Given this list of marker genes RALGPS2, FPGS, VPS35, SEPSECS, ASB4, IMPACT, SLC31A2, RHOU, TRAF3, SERP1, FA2H, ASCC2, GFPT2, SLC7A14, TPST2, GGPS1, CNTN1, FRMD4B, NECAP2 (NCBI Gene Id 55707), EYA1, RELA, AKT1S1, REEP1, ESYT2, ELK4, NIBAN2, LRRC57, SLC25A39, DENND6A, LRIG1, ETNPPL, SLC35B2, BCAT1, IPO8, MYORG, FAM53B, ZKSCAN4, ITGA7 (NCBI Gene Id 81988), TFEB, ENPP4, IL9R, CDCA7, FMC1-LUC7L2, RYR2, MOCS1, GLRB, ENAH, KCNK2, CDH2, BLOC1S6, CHST14, NRP1, CDK6, SLC39A9, FAM177A1, CCDC28A, RASGEF1A, KIF13B, TTL, ROCK1, GPATCH8, ZCCHC24, SERTAD3, SLITRK6 (SLIT and NTRK like family member 6), GRID1, TRIM49D2, RAPGEF1, ZSCAN22, TMEM134, ATF7, MAPK14, GLCE, NR4A1, FAM78B, HADHA, CTDSP1, RCOR1, OSBPL11, SNX18, MYRIP, PLSCR3 (phospholipid scramblase 3), CHST1, UNC119B, NAP1L5, PLEKHM3, MIGA1, MEF2A (NCBI Gene Id 4205), ITPR3 (inositol 1,4,5-trisphosphate receptor type 3), GARIN1A, RNF128, ANKRD27, STEAP3, BCL7A, PGM2, PLEKHF2, P4HA1, RALGDS, ITPRID2, CHIC2, FURIN, SGPP1, MYH11, BTBD10, CPD, VPS37C, APLN, ABCC4, CNKSR3, TRIM49C, RAB3D, ZFP36L2, PCSK6, SGMS1, JAKMIP3, G3BP1, FAM78A, SUCLG2, RFX3, ZBTB20, TRIB3, FLOT1, VAT1, FBXO38, RASSF8, DLX3, TARBP1, FRMD6, PROX1, USP2, DLL4, SPTLC1, TET1, PPP1R13L, HIVEP1, CCDC89, APBB2, ANAPC7, ABT1, SERTAD4, YEATS2, BCL2L13, STOM, ADCY9, RAD17, TADA2B, BCL11B, PML, RHOG, CDH4, CLMP, IREB2, SESTD1, CEBPA, NFIX, KIAA1671, FLRT3 (NCBI Gene Id 23767), SLC2A13, JAM2, LRRC1, WNK1, PARP8, MYRF, GATA6, GDAP1L1, PTPN14, PLXNB2, CAV1, PRKAG2, ANKLE2, PRTG, PAQR9, CLOCK, CADPS (calcium dependent secretion activator), SHC1, TUB, SHANK2, RASSF3, RWDD4, SGK1, ZMPSTE24, TMEM178A, VIM, GDAP2, WDR44, CHP1, CUL5, PTBP1, STON2, CYP2R1, SLITRK4, PARD3, MAGT1, SNTA1, GCDH, XKR6, FAM199X, GIT2, FAM171A1, WDFY3 (WD repeat and FYVE domain containing 3), RALA (NCBI Gene Id 5898), LIMS1, SLC17A5, DSG2, SUSD6, SRGAP1, FAR1, FERMT2, CHIC1, PNPLA2, RAB11FIP1, NFIC, KATNBL1, CLDND1, SPOPL, SH2B3, RNF217, SLC7A1, EYA3, MARCHF8, TMEM150A, KIF2A, CDCP1, NFIB, LUC7L2, NID1, DYRK2, HECTD2, SAP30L, SMOX, PTPRZ1, KCNJ6, PTPRQ, PGRMC2, STT3A, RAI14, SLC33A1, CALCOCO1, MTR, CSPP1, IL6R, SBNO2, NAPEPLD, MAN2A1, MBNL3 (muscleblind like splicing regulator 3), SNIP1, PABPC4L, HTATIP2, GZF1, ZNF503, MORC4, VAMP3, RPIA, WIPF1, TEAD1, NEMP1, MAP3K1, KCTD8, GLI3, TBC1D9B, MED26 (NCBI Gene Id 9441), CBX2, PHACTR2, RAB10, TOR3A, CYB5A, EVI5, HADH, AMMECR1, LPP, GCH1, NAA15, PHKA1, NR5A2, SLC25A38, SVIP, KLHL24, SPCS2, TNFSF15, SGCZ, ASPA, PSKH1, TMEM248, ZMAT3, MAP3K2, CREB3L2, GSN, ARL5B, TRIM49, SLC15A4, TMEM109, TSKU, FCHSD2, SSH1, CTDSPL, CREBRF, FAM120C, FRMD8, RRAGD (Ras related GTP binding D), SLC31A1, SH3KBP1, PRDM13, SEC13, SEMA6A, LAMP2, B4GALT1, PAQR8, RBL1, ENY2, SCAMP4, ATF7IP, RNPEPL1, ZKSCAN8, EDNRB, ETS1, WASF1, GGA2, TWSG1, RAVER1, HIPK3, KPNA3, SLC13A1, GRIA4 (NCBI Gene Id 2893), SLC9A9, OSBPL8, CASQ2, UBE2G1, MAPK4, TLL1, PAM, SUGT1, PIP4K2C, FLOT2, RPS6KA1, MTM1, PPP1R3B, LCLAT1, SHC3, DMD, GNG2, FSBP, PIK3C2A, MKX, CCDC177, CCDC86, AP1M2, PABIR2 (NCBI Gene Id 159090), TMEM104, MLXIP, GXYLT1, KAT7, UNC5D, TEX261 (testis expressed 261), XPO4, EDEM1, RAB34, SEPTIN10, PPARA, HIPK1 (homeodomain interacting protein kinase 1), ARFIP1, MYZAP, MINAR1, USP14, RAB3GAP1, TLN1, PAPOLG, GNAI1, ATMIN, C9orf72, PIEZO2, PHF8, CGN, ATP6V0E1, PLEC, RSRC2, FNBP1, SGPL1, AHR, TOR1AIP2, HEBP2, NYNRIN, SLC30A7, DMRT1, PPIF, OSBP, KIAA2013, DCTN4, WASF2 (NCBI Gene Id 10163), PRRX1, ERN1, QSER1, RBMS3, IRF2BPL, UBE3A, SLC44A5, KCNK10, GTF2A1, MGAT4A, GALNT10, TSC22D4, CD164, FZD4, TFDP2, IQGAP2, LIF, USP30, RAD54B, PPM1F, SOX8, HMGXB4, CPT1A, DLX5, GMNC, AKT3, NFATC1, ADNP2, ZBED4, NR3C2, USP45, RAB22A, CDH9, SREK1, CDON, SDF2L1, OGFOD3, ZNF219, SMARCAD1, TMBIM1, WTAP, KIF26A, PCDH8, MYO1C, TMED1, IAPP, FARP1, MTCL2, GPT2, EPS8, CBFB, MYADM, RAPH1, SNX30, SERTAD2, PALLD, GPAM, XYLT1, PDPR, MIB1, GRIA3, EEA1, RIF1, PKN2, SLC50A1, ARHGDIA, SLC10A7, TP53INP1, STK38, MITF, COL4A1, THRB, TMEM87B, CASP9, RBM20, MYLIP, EML6, PIM1, PTBP3, ILDR2, PI4K2B, CBL, KIF3A, PARP14, ZNF608, CPA3, PLOD3, THAP2, JADE1, THSD7B, IQGAP1, UBQLN3, SFT2D2, DNAJC1, MYH10, ACAA2, SLC35A4, ELAPOR2, NFATC2, TMEM184B, RBM47, ABHD5, NSUN2, CAPN6, SMAD5, SEMA6D, CXADR, ACADVL, POC1B, ELOVL5, ARMC1, SNAP29, HIVEP3, SCAMP2, SLC9A2, ORC2, JAG1, BPNT2, NAT8L, PTTG1IP, ATP1A1, BACH2, ROR2, RNF19A, SELENOI, ELL2, SNX16, TMC7, CHODL, RARG, ANXA5, ACTN4, RYR3, EYA2, TNRC6B, LITAF, TRIM49D1, SUCO, PLP2, ZFP36L1, RNF135, GOLM2, HEATR1, QKI, KIF26B, CCDC198, SYT14, TRIM48, IFFO2, RYK, ANTXR2, C2orf68, C2CD3, PRLR, L2HGDH, PTPRD, SIGMAR1, RIOX2, SLCO5A1 (NCBI Gene Id 81796), AMOTL1, PTBP2, OSBPL10, RBMS1, MYO10, LRRC58, CNEP1R1, ERMP1, OAF, RDH10, KLF6, SORD, RAB38, CPNE3, C1GALT1, LDLRAP1, GMFB, GPR37, MICAL2, MYH9 (NCBI Gene Id 65212), PTPN12, SLC16A13, SLC25A30, FKBP15, SERINC2, EYA4, E2F5, NEK6, AFF4, ZNF131, BMP6, CDK13, RREB1, ATP7A, ECI2, RAB27A, UBE4A, TSHZ1, OSBPL3, PTPN9, ANKRD44, PLEKHH1, ATP6V0A2, NEURL1B, ATL3, SH3PXD2A, FCHO2, TMCO3, NCOA4, LAMC1, GNG10, CD151, ITGA3, FSTL5, GNAL, PECR, PARP16, CAPN2, LCP1, ZWINT, SEPTIN9, NTAQ1, RYR1, HDAC4, CTNND1 (NCBI Gene Id 82168), RHBDF1, TMEM35B (transmembrane protein 35B), TRIM45, RFX4, CAPN1, SNAI2 (NCBI Gene Id 6591), LIMCH1, TRAM2, ZDHHC3, SOS2, CPNE5, SUMF1, PDLIM5, TTC7A, RAB11FIP5, POLR3G, NMNAT1, PAPSS2, ZNF706, MBOAT2, C2orf88, WIPF2, SPINDOC, ARHGEF37, RGS9 (regulator of G protein signaling 9), LEMD3, RBM33, SLC66A3, FMOD, CUX1, SLC1A4, ECE1, MYO1E, USP1, ULK2, GALNT13, C2orf69, LPCAT3, ELK3, ALDH9A1, DNAJC25-GNG10, ENDOD1, CHSY1, STK35, NFAT5, DNASE2, THBS2, OVOL2, GLT8D1, CELSR1, ANXA11, KATNA1, SVIL, SMCO4, EPHA3, GMCL1, EGR2, NME4, SPPL2A, EIF3B, AMOT, TBX22, EGR1, LPIN1, PEA15, GPALPP1, ALDH1L2, ANXA7, DDX3X (NCBI Gene Id 730543), SRSF6, TMEM41A, ACSL1, SLC16A1, GRB2, SMARCC1, AIF1L, SCD (stearoyl-CoA desaturase), STK26, SLC25A37, PUS10, ARFGEF2, TNFRSF11B, DENND1B, SCAF11, RBM24 (NCBI Gene Id 221662), KANK1, RXRA, KLLN, SNTB2, STX10, PDCD6, KLHL28 (NCBI Gene Id 54813), RANBP10, PLXNA3, LMBRD1, PRKG1, RASSF5, ARHGAP28, EFCAB14, CC2D1B, CEP85L, WIPF3, SLC22A5, DUSP3, CTDSP2, ZBTB11, HIVEP2, PPFIBP2, MANBAL, FOXQ1, MTMR10, DMRTA1 (DMRT like family A1), TJP2, BICC1, HIF1AN, TWIST2, YME1L1, ALG2, CERS2, POGLUT1, PHF19, ITGB1, LMAN2L, CRTC3, GRIA2, PDE4B, PTPRJ, SP1, SLC35G1, RHOQ, MCUR1, ST3GAL1, CACUL1, RFFL, SIX4, here is a description of the gene set: Human Gene Set: MIR124_3P studied in species Homo sapiens from publication Chen Y, Wang X (PMID 31504780) Genes predicted to be targets of miRBase v22 microRNA hsa-miR-124-3p in miRDB v6.0 with MirTarget v4 prediction scores > 80 (high confidence targets).